Given this list of marker genes DGUOK, GJB6, DKK1, ERCC6, ERCC8, here is a description of the gene set: Human Gene Set: HP_ADULT_ONSET_SENSORINEURAL_HEARING_IMPAIRMENT Adult onset sensorineural hearing impairment studied in species Homo sapiens The presence of sensorineural deafness with late onset.